The following is a description of a gene set: Human Gene Set: GOMF_RNA_POLYMERASE_III_TRANSCRIPTION_REGULATORY_REGION_SEQUENCE_SPECIFIC_DNA_BINDING species: Homo sapiens Binding to a DNA region that controls the transcription of a gene by RNA polymerase III. Binding may occur as a sequence specific interaction or as an interaction observed only once a factor has been recruited to the DNA by other factors., and this is the list of marker genes: GTF3C5, MAF1, BRF2, PRDX5, SNAPC4, SNAPC3, MTOR, BRF1